Given this list of marker genes CCND1, PTK6, CDK4 (cyclin dependent kinase 4), CDKN1B, CDK2, CCNE1, here is a description of the gene set: studied in species Homo sapiens Human Gene Set: REACTOME_PTK6_REGULATES_CELL_CYCLE PTK6 Regulates Cell Cycle